The following is a description of a gene set: from publication Ellwood-Yen K, Graeber TG, Wongvipat J, Iruela-Arispe ML, Zhang J, Matusik R, Thomas GV, Sawyers CL (PMID 14522256) Mouse Gene Set: ELLWOOD_MYC_TARGETS_DN species: Mus musculus Increased Myc gene copy number is observed in human prostate cancer. To define Myc's functional role, we generated transgenic mice expressing human c-Myc in the mouse prostate. All mice developed murine prostatic intraepithelial neoplasia followed by invasive adenocarcinoma. Microarray-based expression profiling identified a Myc prostate cancer expression signature, which included the putative human tumor suppressor NXK3.1. Human prostate tumor databases revealed modules of human genes that varied in concert with the Myc prostate cancer signature. This module includes the Pim-1 kinase, a gene known to cooperate with Myc in tumorigenesis, and defines a subset of human, Myc-like human cancers. This approach illustrates how genomic technologies can be applied to mouse cancer models to guide evaluation of human tumor databases. Genes down-regulated in transgenic mice expressing human MYC in prostate., and this is the list of marker genes: Anapc16, Pex2, Limch1, 4931406C07Rik, H2bc4, Cds2, Prom1, Pttg1ip, Satb1, Erp44, Mcfd2, Mcoln2, Ormdl3, Phyh, Trp53inp2, Nr1d2, Mtarc2 (mitochondrial amidoxime reducing component 2), Smim14, Ide, Mrps34, Dnajc10, Inpp5b, Fmod (NCBI Gene Id 98597), Bglap3, Ufc1, Tmem97, Fkbp2, Chmp2a, Dazap2, Aldh2, Rnf149, Ezr, Tmed4, Lamtor2, Tmem170, Egf, Pdia6, Ganab, Tmed3, Nkx3-1, Car2, Cldn4, Tmprss2